The following is a description of a gene set: Any process that activates or increases the frequency, rate or extent of cell maturation. Mouse Gene Set: GOBP_POSITIVE_REGULATION_OF_CELL_MATURATION species: Mus musculus, and this is the list of marker genes: Clec7a, Ngf, Grip2, Mtor, Ret, Sirt2, Adam7 (a disintegrin and metallopeptidase domain 7), Tmprss12, Bcl2, Bnc1 (basonuclin zinc finger protein 1), Aurka (NCBI Gene Id 99385), Map3k13, Runx1, Opa1